Given this list of marker genes ZMYND8, BAG4, ANLN, FES, LINGO2, MOAP1, CDK5RAP2, ZMYND10 (zinc finger MYND-type containing 10), WARS1, TENM1, SLAIN1, LRRTM2, CLRN1, MLST8, FER, CTTN, SNX30, IFT20, EPHB2, AKIRIN1, HDAC6, SLITRK3, CRB3, EPHA2, VPS4B, EMILIN1, IL1RAP, TGFB1, MAPRE1, CRACD (NCBI Gene Id 57482), EPB41L5, NUMA1, NRXN1, CDC42EP2, POLDIP2, CCN2, PPM1E, TESK1, FRMD7, TNF, THBS2, ABI2, SKAP1, TRIM65, CENPJ, EPHB1, NTRK3, HGS, DOCK11, SLX1B, NLGN2 (neuroligin 2), ROCK2, TTBK1, MYO3A, MIR27B, CYFIP1, NPHP4, CCL21, CKAP5, LINGO4, TENM2, SNX7, CCP110, SNF8, F2RL1, ABCA1, CDC42, PLEKHM1, CDH17 (NCBI Gene Id 1015), WNT1, RHOA, PSMC6, IL17A, PYCARD, IRX3, FLRT3, GIT1, HSPA1A, ICE1, CUX2, PSMC5, PIK3CA, RAPGEF3, TLR6 (toll like receptor 6), SRF, AMIGO3, RACK1, PALM, AGT, GRID2, HAS3, SORBS3, DSG3, ARHGEF5, WNT10B, MECP2, ARL2, SH3GLB1, SLITRK5, NLGN3, KCNK6, ATG2A, SLITRK6, ERCC1, PRKCE, TFRC, PSRC1, BBC3, LRRN1, MAPK8, ARAP1, SASS6, MYD88, LIMCH1, WASHC2C, PTPN22, SERPINF2, LRRC24, IFNG, GBP5, GSK3B, BRK1, CX3CL1, TAL1, VPS4A, SEPTIN9, TPBG, SEMA4A, PPM1F, ARHGEF10L, CLASP1, PIP4K2A, ARHGEF10, TGFB3, SRPX2, NCK1, SDC4, CAND1, NAV3, FERMT2, BECN1, ENTR1, HSF1, WIPI1 (WD repeat domain, phosphoinositide interacting 1), PFN1, NPHS1, NCKAP1, STX18, SLF1, RALB, TIRAP, ISG15, TPR, TPPP, LRRTM3, BRAF, CAPG, PIP4K2B, APOE, LRSAM1, CCDC15, RGCC, ADNP, USP16, TRABD2B, NDEL1, WASF2, AMOT (NCBI Gene Id 23340), TPM1, STUB1, TRABD2A, CNTNAP2, NLGN1, CCL26, SYNPO, MIEN1, CAPRIN1, ST8SIA2, BMP7, HCK, PLK4, FLRT1, IQSEC2 (IQ motif and Sec7 domain ArfGEF 2), MTOR, MMP1, CROCC, IFT88, RAC2, FCHSD1, NEURL1, GRB2, CLEC7A, SLITRK2, NRP1, ADGRB1, RASIP1, LRRN3, ZDHHC1, CRBN, MTLN, PPP2CA (NCBI Gene Id 5515), PLPPR5, BIN1, CDK5R1, ARMCX5-GPRASP2, MNS1, NF2, RAB3GAP2, ADGRB3, SKA1, CAV1, KDR, CDH5, BAK1, MYO3B, BTK, AMIGO2, MMP3 (matrix metallopeptidase 3), AKAP9, BDNF, APOA1 (apolipoprotein A1), CBLN2, CDC42EP3, WRAP73, C15orf62, DCTN1, ATMIN, PIP4K2C, EPHB3, ABCA3, VSTM5, FAM98A, SFRP1, CEP135, CARMIL1, BID, ARHGAP35, CAV3, WASHC1 (NCBI Gene Id 727741), EVL, SLF2, CCDC88A, AUTS2, RAB3GAP1, RALA, ATP13A2, EPS8, MET, NRG1, PTPRJ, PRKCA, BAIAP2L1, PAN2, GDF2, GPRASP3 (G protein-coupled receptor associated sorting protein family member 3), HRG, GNL3L, FERMT1, ROCK1, COBL, ALOX15, HOPX, MARCHF5, GPSM2, ATM, DDX3X, AGRN, FSCN1, CSF3, PFN2, LMOD2, CLDN1, ZDHHC5, GBP2, SLAIN2, TPPP2 (NCBI Gene Id 122664), BAX, CEP120, VCP, PLEK, SNX9, CLU, VEGFA (vascular endothelial growth factor A), CNOT6L, PFN3, DRG1, SYNPO2L, RAC1, RHOC, OCLN, CNOT6, ANKRD53, HSPA1B, PTPRD (NCBI Gene Id 5789), NR1H2, ATG5, MAPK9, MSTN, WNT4, GPM6A, WASL, ASIC2, COL16A1, LIMS1 (NCBI Gene Id 3987), UNC13B, SEMA4D, CD36, LRRC4B, TACR1, TOGARAM1, USP50, RICTOR, CSF2, TSC1, RP1 (RP1 axonemal microtubule associated), BAIAP2L2, NEK7, CCL19, CCL24, CLDN5, PXN, PPP1R35, DPYSL3, STAU2, NTRK2, TSG101, GPR65, RPS3, CEP295, FLRT2, HRK, SDCBP, MTSS1, RAP1B, CFL1, HTT, EPHA1, SNX18, CDC42EP1, SYNDIG1, FCHSD2, TPPP3, HAP1, GHRL, CCL11, DZIP1, EEF2K, CDC42EP5, DEF8, SLITRK1, SMPD3, SOX9, LMOD1, AJUBA, ARPC2, CREB1, PIK3R1, ATAT1 (alpha tubulin acetyltransferase 1), SMAD4, THY1, VIL1, MAP1B, PINK1 (NCBI Gene Id 65018), LATS2, FNIP1, TAPT1, CNOT2, CBLN1, DAB2IP, AMIGO1, NTRK1, BCL2L11, PDE4DIP, P2RY12, STAM, NUP62, PARK7, NCK2, HRAS, SPIDR, FNBP1L (formin binding protein 1 like), PPP2R5B, MAP4K4, SNCA, RAB7A, EFNA5, UBAP2L, OXT, MAPK15, EPS8L3, TGFBR1, FHOD1, P2RX7, IL5, TLR4, TRIM32, PDCD6IP, FLOT1, MED25, LRTM2, MYOC, FUZ, ITGB1BP1, ULK1, CLIP1, DYNC1H1, MARK4, CLSTN2, TWF2, SEPTIN7, WNT7A, CHGA, ELAPOR1, LRRTM1, STIL, BRCC3, SYNPO2, TP53, LPAR1, ADGRB2, VASP, TTBK2 (tau tubulin kinase 2), HSP90AA1, APC, BAIAP2, CDKN1B, LGALS3, S100A10, CDK2, CARMIL2, ATR, PRKD1 (NCBI Gene Id 5587), ACE2, CLSTN3, DHX33, AMBRA1, DLG5, IL1RAPL1, LCP1, PLEK2 (NCBI Gene Id 26499), CLSTN1, PTK2B, EPS8L1, ABL1, SPAG5, SAXO1, PAN3, HYAL1, WDR45, NPHP1, PAK1, SRC, SLITRK4 (NCBI Gene Id 139065), SLX4, SDC1, TERF1, CDC42EP4, TEK, BIK, TAC1, ARF6, BBS4, EPS8L2, SYK, LDB2, CCR7, ACTR2, ACVRL1, KIT, ARHGEF15 (Rho guanine nucleotide exchange factor 15), PLCG2, ACTR3, CHMP2A, POC1B, DLG1, KCTD17, CNOT1, RIPOR2, FNIP2 (NCBI Gene Id 57600), FLNA, SLX1A, SWAP70, AVIL, SUMO1, KIRREL1, SMAD3, MAVS, NCKAP1L, CD47 (CD47 molecule), TBX5, LIMK1, RAB11FIP3, FMR1, STMP1, MPP7, MAPT, EIF4G1, PLCE1, RHOQ, SNX4, CXCL13, MSN, BMF, HIP1R, PIEZO1, LATS1, here is a description of the gene set: species: Homo sapiens Any process that activates or increases the frequency, rate or extent of cellular component biogenesis, a process that results in the biosynthesis of constituent macromolecules, assembly, and arrangement of constituent parts of a cellular component. Human Gene Set: GOBP_POSITIVE_REGULATION_OF_CELLULAR_COMPONENT_BIOGENESIS